The following is a description of a gene set: A localization process that acts on a protein complex; the complex is transported to, or maintained in, a specific location. Mouse Gene Set: GOBP_PROTEIN_CONTAINING_COMPLEX_LOCALIZATION studied in species Mus musculus, and this is the list of marker genes: Vamp2, Rnf216, Cluap1, Lhfpl4, Rbm10, Myo5b, Itgb1, Dok7, Dync2i1, Gsg1l, Tsc1, Ift22, Rcc2, Neto1, Zdhhc3, Bbs1, Stx4a, Tspan7, Seh1l, Washc5, Pacsin1, Zdhhc2, Dlg3, Ogt, Gripap1, Nlgn1 (NCBI Gene Id 99949), Clstn1, Fcgr4, 1700009N14Rik, Tnfaip2, Cnih2, Epg5, Wdpcp (WD repeat containing planar cell polarity effector), Grip2, Rap1a, Atad1, Snapin, Klc3, Nptxr, Cacna2d2, Traf6, Ccdc38 (coiled-coil domain containing 38), Slc1a1, Efnb2, Tmem108, Nmd3, Ift56, Mapk10, Nedd4l, Agrn (NCBI Gene Id 381587), Usp46, Rab7, Mak, Gabarap (NCBI Gene Id 56486), Eif6, Snap23, Cep112, Nop9, Rab11a, Klhl21, Hpca, Grin2a, Ift25, Stx3, Susd4, Tub (TUB bipartite transcription factor), Lrrc7 (NCBI Gene Id 319537), Kifap3, Nedd4, Syt17, Ap2b1, Rps15, Ighe, Dag1, Ift43, C1ql2, Ndc1, Fuz, Rnf220, Ssna1, Ift70b, Kif3b, Mios, Prkcz, Dnm3, Sh3glb2, Akap6, Cplx1, Ezr, Dlg4, Ap3d1, Nptx2, Eps15, Gpc6 (NCBI Gene Id 77735), Nsg1, Dlg1, Drd4, Lgi1, Ift57, Cacng4, Sirt2, Lpar1, Traf3ip1, Gpsm2 (NCBI Gene Id 76123), Ap2m1, Cep131, Rdx, Ift122, Scrib, Cacng3, Ttc21a, Ran, Tamalin, Dlg2, Dync2i2, Ap2s1, Dbn1, Dynll1, Snx27, Ralgapb, Cacng2, Snap47, Cacng8, Ophn1, Rapgef4, Rala, Cblb, Mzt1, Ttc21b, Mkln1, Kifc2, Camk2a, Lmnb2, Vwc2, Neto2, Bbs12, Nptn, Nptx1, Myo6, Ift52, Cacng5, Mylk, Arhgap44 (Rho GTPase activating protein 44), Iqsec2, Rab4a, Arl3, Ppp3r1, Drd3, Ghsr, Fcer2a, Rabep1, Tspan9, Riok2, Xpo1, Itgb3, Akap5, Ssx2ip, Ift74 (NCBI Gene Id 67694), Nrxn3, Wdr35, Rab8a, Ap3m1, Kalrn, Vps35, Ift172, Dnmt3b, Fcmr, Ift140, Hap1, Musk, Exoc3l4, Hras (NCBI Gene Id 15461), Gphn, Pip5k1c, Lmnb1, Akirin2, Grip1, Nacc2, Erbb4, Cacng7, Sacm1l, Rpgr, Adam10, Git1, Nrg1, Nme7, Exoc3, Ncdn, Ift81, Numb, Fkbp4, Cnih3, Ift27, Kif5c, Wasl, Iqsec1, Atm, Kif3a, Ltv1, Caly, C1ql3, Map2k1, Ift80, Epb41l1, Pick1, Ipo9, Daw1, Mdn1, Sdad1, Adam22, Vac14, Dync2li1, Ralgapa2, Dzip1, Pml, Ap2a2, Cep72, Rab11fip5, Intu, Dynlt2b, Ift70a2, Kif5b, Nbea, Hip1, Wdr19, Olfm2, Lsg1, Vps26b (VPS26 retromer complex component B), Ralb, Exoc3l, Nrxn1, Ift88, Tmem232, Kif17, Lmna, Zfp365, Lrp1, Lca5l, Tacc3, Erbb2, Spag17, Kif5a, Arc (activity regulated cytoskeletal-associated protein), Rapsn, Gsk3b, Magi2, Nup88, Stx7, Fxr1, Gpc4, Tyrobp, BC048507, Cilk1, Reln, Ap2a1, Ift46, Pcm1, Sgcd, Anks1b, Slc12a5, Ift70a1, Mdm2, Fcgr2b (NCBI Gene Id 98391), Akap9, Exoc3l2, Smad7, Birc5, Tnik, Synj1, Kif2c, Rasl2-9, Npm1, Dync2h1, Ift20, Lca5, Shisa6, Stx1b